The following is a description of a gene set: A fatty acid beta-oxidation pathway in which the initial step, which converts an acyl-CoA to a trans-2-enoyl-CoA, is catalyzed by acyl-CoA oxidase; the electrons removed by oxidation pass directly to oxygen and produce hydrogen peroxide, which is cleaved by peroxisomal catalases. Fatty acid beta-oxidation begins with the addition of coenzyme A to a fatty acid, and ends when only two or three carbons remain (as acetyl-CoA or propionyl-CoA respectively). Human Gene Set: GOBP_FATTY_ACID_BETA_OXIDATION_USING_ACYL_COA_OXIDASE studied in species Homo sapiens, and this is the list of marker genes: CRAT, ACAA1, HSD17B4, CROT, ACOT8, DECR2, ACOX1, SLC27A2, ACOX2, ACOX3, SCP2, AMACR, ACOXL, EHHADH